The following is a description of a gene set: Genes up-regulated in naïve CD8 T cells compared to effector CD8 T cells at contraction phase (day 15 after LCMV-Armstrong infection). studied in species Homo sapiens from publication Kaech SM, Hemby S, Kersh E, Ahmed R (PMID 12526810) Human Gene Set: KAECH_NAIVE_VS_DAY15_EFF_CD8_TCELL_UP How and when memory T cells form during an immune response are long-standing questions. To better understand memory CD8 T cell development, a time course of gene expression and functional changes in antigen-specific T cells during viral infection was evaluated. The expression of many genes continued to change after viral clearance in accordance with changes in CD8 T cell functional properties. Even though memory cell precursors were present at the peak of the immune response, these cells did not display hallmark functional traits of memory T cells. However, these cells gradually acquired the memory cell qualities of self-renewal and rapid recall to antigen suggesting the model that antigen-specific CD8 T cells progressively differentiate into memory cells following viral infection., and this is the list of marker genes: TTC3, GSN, CHRNB1, PPIC, PLAUR, HAGH, ZFR, RPS6, IKBKB, RAMP1, SQOR, GALK1, GSTT2, AMPD3, SNHG6, OXCT1, ST6GAL1, WASHC3, SARAF, PWP1 (PWP1 homolog, endonuclein), PRDX6, MRM3, PDK1, VAPA, EXT1, WDR1, TLR6, SCN10A, ATP6V0A2, ITGAE, RPS2, YJU2B, C15orf39, PAPOLA, LRWD1, ZNRF1, IKBKE, KCNN4, ANKRD10, NEDD4L, SEC11C, MPP1, ACADM, ADAR (NCBI Gene Id 3427), RGS10, SPSB1, RPSA, SFMBT2, MORF4L2, HPCAL1, SESN1, PA2G4, MPHOSPH9, PTOV1, EPB41L4A-AS1 (EPB41L4A antisense RNA 1), CD7, RGCC, GRIA3, APEX1, SF3B3, SLC25A15, IL6R, SELENOH, DNTT, ABCC5, NDUFB5, WLS, ID3, ITPKB, PELI1, MFHAS1, SLC12A7, RPS3, GABRR2, PYCR2, DGKA, YY1, ITK, BZW2, PATJ, SPRED2, NSG2, CXXC5 (CXXC finger protein 5), SPTBN1, MCCC1, IPO4, HDAC5, DNAJC7, IFRD2, CTSV, ENG, NCBP1, METTL9, H19, TMEM223, PHPT1, ADD1, CCDC152, RFLNB, DAG1, NAB2, SRM (NCBI Gene Id 6723), MBTD1, BIRC2, PRKD2, DDX21, LDLR, ACTN1, SH3BP5, MOGS, TUBB, PSMD6, SRCAP, SSBP2, HOXA5, TIMELESS, ADCY6, HDAC2, TEC, ELOVL5, GSTK1, CDK16, SATB1, IDH2, NR2C1, TUBB6, PSME1 (NCBI Gene Id 5720), DNAJB2, CD8A, CD5, ARMCX2, POLR3A, QRICH1, PCCB (NCBI Gene Id 5096), LMO4, GALNT11, KLK8, GALNT2, AIMP2, ARRB1, SLC30A4, LEF1, AKAP9, PIP4K2A, RACK1, MGST2, RPL10, LIPA, SERPINI1, PSMB10, PLEKHA1, TBCEL, METTL3, NAT1, RPS6KA2, IL4R, DDX50, IL6ST, ETS2, MRPL23, RPS8, CTPS1, EPHX1, EML5, SMAD7, VPS37B, NPC2, HSD17B10, SMC4, FNTB, CSAD, CD247, DDC, RNASET2, P4HA1, EVL, SELL, RETREG1, SMAD1, OR4C3, CD46, TTC27, CRLF3, EEIG1, ABLIM1, EMB, TDRP, GGT5, ORC4, ACP5, EYA2, WDR6, USP3, CCR7, GRK6, TNFAIP8L1, RAB3IP, PRMT3, GBP2, CCR9